Given this list of marker genes Cd44, Pik3cd, Hcar2, Anxa1, Pik3cb, here is a description of the gene set: Mouse Gene Set: GOBP_POSITIVE_REGULATION_OF_NEUTROPHIL_APOPTOTIC_PROCESS species: Mus musculus Any process that activates or increases the frequency, rate, or extent of neutrophil apoptotic process.